Given this list of marker genes HAS1 (NCBI Gene Id 3036), STAB2, HAS3, CEMIP, HYAL1, CD44, GUSB, HMMR, LYVE1, HYAL2, CHP1, HYAL3, HAS2, ABCC5, HEXA, HEXB (NCBI Gene Id 3074), SLC9A1, here is a description of the gene set: Human Gene Set: REACTOME_HYALURONAN_METABOLISM Hyaluronan metabolism studied in species Homo sapiens